Given this list of marker genes NACAD, BTF3, NACA2, NACA4P, NACA, here is a description of the gene set: Human Gene Set: GOCC_NASCENT_POLYPEPTIDE_ASSOCIATED_COMPLEX A heterodimeric protein complex that can reversibly bind to ribosomes, and is located in direct proximity to newly synthesized polypeptide chains as they emerge from the ribosome. studied in species Homo sapiens